Given this list of marker genes SLC25A22, NEUROD2, KCNH5, CASK, MTOR, KCNA1, GRIA3, SCN2A, PIK3CA, CLCN4 (chloride voltage-gated channel 4), SCN1B, SIK1, SCN8A, CDKL5, GRIN1, KCNQ3, PNKP, WWOX, PIGP, PURA, PRRT2, PIGQ, SLC32A1 (NCBI Gene Id 140679), DMXL2, GNAO1, WDR45B, KCNQ2, CACNA1A, PACS2, GRM7, OTUD7A, TRIM8, KCNT1, ARX, AKT3, EN1, SLC1A2, NGLY1, here is a description of the gene set: Human Gene Set: HP_FOCAL_TONIC_SEIZURE Focal tonic seizure A type of focal motor seizure characterized by sustained increase in muscle contraction, lasting a few seconds to minutes. studied in species Homo sapiens